Given this list of marker genes IL33, IL1RL1, IL1RAP, here is a description of the gene set: part of: Interleukin-1 family signaling species: Homo sapiens Interleukin-33 (IL33) cytokine is a member of the Interleukin-1 family. It can be classified as an alarmin because it is released into the extracellular space during cell damage. It acts as an endogenous danger signal.] The gene product is biologically active (full-length IL33). Its potency has been reported to increase significantly (up to 30x) after cleavage at the N-terminus by inflammatory proteases such as Cathepsin G (CTSG) and Neutrophil elastase (ELANE) but others have suggested that processing inactivates IL33 (Cayrol & Girard 2009). IL33 can act as an extracellular ligand and an intracellular signaling molecule. Full-length IL33 has a nuclear localization sequence and can translocate to the nucleus, where it binds heterochromatin. IL33 that has undergone proteolytic processing is unable to translocate to the nucleus. Binding of extracellular IL33 to its receptor Interleukin-1 receptor-like 1 (IL1RL1, suppression of tumorigenicity 2, ST2) initiates several cellular signaling pathways. Cell injury or death are the dominant mechanisms by which IL33 reaches the extracellular environment, IL33 is not actively secreted by cells. Because IL33 is expressed constitutively by endothelial and epithelial cells it is immediately available to the extracellular microenvironment after cell injury and necrosis. Increases in extracellular ATP or mechanical stress correlate with increased IL33 secretion by mast cells or cardiomyocytes, respectively. Soluble IL1RL1 (IL1RL1 Isoform C, ST2V) shares the extracellular components of IL1RL1, including the ligand binding domain, but lacks the transmembrane and intracellular components of IL1RL1. The IL33-IL1RL1 complex recruits a co-receptor, most commonly IL1 receptor accessory protein (IL1RAP, IL-1RAcP). Reactome Pathway: Interleukin-33 signaling